The following is a description of a gene set: Human Gene Set: RUBENSTEIN_SKELETAL_MUSCLE_SMOOTH_MUSCLE_CELLS studied in species Homo sapiens from publication Rubenstein AB, Smith GR, Raue U, Begue G, Minchev K, Ruf-Zamojski F, Nair VD, Wang X, Zhou L, Zaslavsky E, Trappe TA, Trappe S, Sealfon SC (PMID 31937892), and this is the list of marker genes: PPP1R12B (protein phosphatase 1 regulatory subunit 12B), MT2A, SNX3, BCAM, CKB, NDUFA8, MT-ND4, BEX4, PRDX2, MYL9, CHMP4A, EIF3H, COX8A, NDUFA4L2, ATP5PD (ATP synthase peripheral stalk subunit d), TPRKB, CAPZA2, RPL5, MORF4L1, ADI1, SOD3, IGFBP5, HES1, HES4, MT-ND3, KCNMB1, NET1, DYNLT1, SKP1, UBE2V2, NPTN, UQCRC1, CYB5R3, RPL9, NSA2, NUPR1, ISYNA1, CNIH4, COX6B1, FIS1, UBE2D2, FBXL13, ZNG1A, RPLP1, RPL14, PARL, UQCR10, CCNI, TMED2, NDUFA5, MEF2C, SNRK, COPS8, PLP2, OTUD6B-AS1, S100A4, SELENOK, PDLIM3, SF3B2, COMMD6, NDUFA10, PTGES3, NDUFS6, GUCY1B1, SLC38A2, MYH11, COX5B, RGS16, KIF5B, UBA2, DKK3, LBH (LBH regulator of WNT signaling pathway), NUDT4, NR2F2, ACTA2, FHL5, MPC1, EIF1B (NCBI Gene Id 10289), PPP1R15A, DCTN2, NDUFB10, FAM162B, CNN1, PALLD, ISCU, MPRIP, CSRP2, FHL1, LMO4, CRTAP, CNBP, NDUFS8, ARHGEF25, PPDPF, COX5A, EIF3K, DYNLRB1, LMOD1, RPL36AL, CHCHD10, COX7B, SLC25A5, PPP1CB, ALDOA, AP2M1, KLHL42, MOB2, JAG1, GHITM, MIR145, RPL4, ITM2C, SEM1, ACTG2, MRPL32, LITAF, CCDC107, ITIH5, NTRK2, SH3BGRL, PHPT1, TMEM14C, TSPO, METTL5, COX7C, CCND1, PRSS23, DBI, ACTB, SLC38A11, UQCRQ, YBX1, GBP2, BBX, PTK2, LDHA, MAPRE2, ZFHX3, KLHL23, MT-ATP6, RPL8, COX17, RCAN2 (regulator of calcineurin 2), COX14, PGAM1, IGFBP7, C11orf96, CALM3, MT-ND2, MAGED2, PKM, RPL7, JUNB, TIMMDC1, VIM, ATP5F1A, COX4I1, CDH6, ARID5A, CCL2, BUD31, ECRG4, CYCS, UBB, BRK1, ATP5MK, PSMC1, ROCK1, NDUFB2, EID1, RPL15, NDUFB11, SBDS, COX7A1, TBCA, COX6A1, COX7A2, ATP5MC2, JUN, GADD45B, SNCG, ATP5ME, UQCRH, SNHG32, DEK, CHMP4B, ARPC5, HIKESHI, CCDC3, SLC25A3, SIVA1, HMGN2, ARPC2, CSRP1, GTF3A, MDH1, RPS4X, RPL6, FOS, MFGE8, IRAG1, TPM1, MGST3 (microsomal glutathione S-transferase 3), FTH1, RPS7 (ribosomal protein S7), MICOS13, PLN, RPS27L, CAMTA1, PNRC1, OPTN, NDUFA13, MT-CO3, RCN2, NDUFB3, ACTN4, ARID5B, CASQ2 (calsequestrin 2), NDUFS7, NIPSNAP2, MYL6, TPM2, SLC25A6, RAB13, NCOR1, SMIM30, PHLDA2, BGN, ENTPD1, MT1M, ENTPD3, NUDC, ATF3, PPP1R14A, RAP1A, CRIP2, NTN4, CALD1, NDUFS4, CCT7, RABGAP1, WDR1, TAGLN, KANK2, MT-CO1, RGS5, MAP3K7CL, NOTCH3, RPL7A, HCFC1R1, NDUFA6, ATP5MJ, ADIRF, MRPS6, RPL37A, GTF2A2, REEP3, CD9, MT-ND4L, SPARCL1, CD151, LDHB, RPL3, RBBP7, VDAC2, CSNK1A1, C1orf43, RANBP1, SOD1, MT-CYB, GTF3C6, FMC1-LUC7L2, ZFP36, BTF3, CALM2, ITGA8, PIP5K1B, CRIM1, EGR1, RAN, UQCRB, PARK7, PHB1, C7orf50, CAVIN3 (caveolae associated protein 3), MRPL33, ANAPC16, MFF, PTN (pleiotrophin), RPL10A (ribosomal protein L10a), SLIRP, H4C3 (NCBI Gene Id 8364), CYC1, FILIP1, MYLK, PSMB6, SDHD, SYNPO2, COX6C, TMEM230, RPS5, ACTN1, PFDN5 (NCBI Gene Id 5204), DDAH2 (DDAH family member 2, ADMA-independent), MAF1, IK, TCEA1, GPRC5C, CYSTM1, PTMA, FAM162A, GAPDH, GUCY1A1, SERPINI1, RSU1, H1-0, PTMS, MT1E, EDNRA, MAP3K13, BAG1, SGCE, UQCRFS1, MAP3K20, PLAC9 (placenta associated 9), RBPMS, STOML2, YWHAQ, MT-CO2, TBX2, TMEM38B, PKIG, TAX1BP1, SAP18, TOMM22, NDUFA1, PGRMC1, FRZB, PPIG, ATP5IF1, MTHFD2, NDUFS5, DDT, TCP1, SPCS1, ZYX, CNN3 (NCBI Gene Id 1266), CSDE1, SORBS2, IDS, RPL41, ATP5F1B, ILK, TSC22D1, COX4I2, PCNP, HACD1, ATP5PB, PTP4A3, ARPC1A, MRPL23, PRDX3, VDAC3, ANXA6, CRIP1, PDCL3, UBL5, RSL24D1 (NCBI Gene Id 51187), RPL23, UQCRC2, SELENOW, RPS25, MSRB3, NDUFA4, PDLIM7, PEBP1, FLNA, CAP1, HIGD1B, LPP, CPM, ATP5MC3, UGP2, ECH1, FAU, TINAGL1, TPI1, VCL, CRYAB, BEX3, MCAM, NPM1 (nucleophosmin 1), NDUFB7, AURKAIP1, OR51E1, ATP5MG, HIGD2A, CPE, SLIT3, EFHD1, DSTN, MAP1B, PPP1R12A, TNS1, STRAP, ATP5F1C, ATP5F1D, AIG1, NDUFV2, ITGB1BP1, CHURC1, LSM5, ZFYVE21, BTG2, MT-ND1, ERGIC2, RBPMS2, LMNA, NDUFAB1, RPS3A, ITGB1, MRPL18, SELENOM, RERGL, ATP6V1G1, TGFB1I1, HNRNPA1, EPS8, ATP5PO, IAH1, AXL, OAZ2, TSPAN3, BTF3L4, MICOS10, FILIP1L, COPS6, AK1, ANP32B, EIF3L, FXYD1, KGD4, SVIL, NDUFB9, COX20